Given this list of marker genes CNDP2, GGT1, GGT7, GGT5, CHAC1, GCLM, OPLAH, GGT6, GSS, CHAC2, GCLC, GGT3P, GGCT, here is a description of the gene set: part of: Glutathione conjugation species: Homo sapiens The combination of glutamate, cysteine and ATP is required to form glutathione. The steps involved in the synthesis and recycling of glutathione are outlined. Reactome Pathway: Glutathione synthesis and recycling